Given this list of marker genes CFAP300, BRWD1, NME5, CLCN7, RSPH9, DNAAF1, SNX10, STK36, RAG1, CFAP74, DNAJB13, ZMYND10, CCDC39, TCIRG1, DNAL1 (dynein axonemal light chain 1), GAS8, RSPH3, SPINK5, TTC12, DNAI1, DNAH1 (dynein axonemal heavy chain 1), DNAH5, ODAD1, OFD1, RSPH1, ODAD4, RAG2, ODAD2, DNAH9, RSPH4A, TNFSF11, CFAP298, ODAD3, DNAAF2, SPAG1, MCIDAS, DNAAF4, SLC29A3, CCNO, CFAP221, DRC1, NEK10, SASH3, DNAAF3, RPGR, ALG12, NME8, LRRC56, FOXJ1, SPEF2, DNAAF6, NLRP1, DNAI2, CCDC103, DNAAF11, DNAAF5, CCDC40, TAP2, GAS2L2, HYDIN, DNAH11, here is a description of the gene set: species: Homo sapiens Human Gene Set: HP_CHRONIC_RHINITIS Chronic inflammation of the nasal mucosa. Chronic rhinitis